The following is a description of a gene set: Human Gene Set: HP_LYMPHOMA Lymphoma species: Homo sapiens A cancer originating in lymphocytes and presenting as a solid tumor of lymhpoid cells., and this is the list of marker genes: TERC, NRAS, STK4, ATM, FCHO1, CHEK2, XRCC4, SH2D1A, CTC1, ZAP70, NHP2, HAVCR2, TNFSF12, RNF43, CHD7, RB1, DIAPH1, APC, RAG1, PRF1, TINF2, HLA-DQB1, CD70, KIF11, IRF2BP2, MS4A1, LIG4, PIK3R1, AAGAB, ASXL1, NOP10, DEF6, KRAS, RAD54L, BLM, LRBA, PMS2, RECQL4, IL2RG, NPM1, HLA-DQA1, KIT, PIK3CD, TET2, CD27, ICOS, TP53, MYC, IGHG2, PTPRC, TNFRSF13C, CTLA4, CDKN2A, FOXP1, PGM3, TNFRSF9, TNFRSF13B, WRAP53, RASGRP1, MDM2, CASP10, BCL2 (BCL2 apoptosis regulator), TTC7A, NSUN2, IL7R, SRSF2, RTEL1, TYMS, CD28, RUNX1, DDX41, NBN, ADA, TERT, RAD54B, STAT6, CR2, MLH1, NFKB2, SYK, WIPF1, XIAP, ITK, IKZF3, RAG2, BIRC3, MALT1, KLHDC8B, RMRP, CD19, WAS, TCF4, TP63, IGKC, HLA-DRB1, NTHL1, FAS, SOCS1, MYD88, CD81, PTEN, BCL6, CCND1, COL14A1, NFATC2, DCLRE1C, SMARCAL1, MSH6, STAT3, POLE, PNP, RHOH, TNFRSF1B, USB1, MAGT1, FASLG, NFKB1, DKC1, PARN, BCL10, DNASE1L3